The following is a description of a gene set: species: Homo sapiens Human Gene Set: GOBP_IMMUNE_RESPONSE_REGULATING_CELL_SURFACE_RECEPTOR_SIGNALING_PATHWAY The series of molecular signals initiated by an extracellular ligand binding to a receptor on the surface of the target cell capable of activating, perpetuating, or inhibiting an immune response., and this is the list of marker genes: CD40, NFAM1, TNIP2, LAPTM5, EP300, BTNL10P, TRAF3, CRKL, LIME1, KLRC4-KLRK1, RNF31, FCN2, HLA-A, RABGEF1, RFTN1, OAS1, GPS2, CD19, FCHO1, IFNG, IGHG4, PLEKHA1, NCKAP1L, SPG21, PVRIG, MAP3K7, FCGR2B, CD3E, IGHG1, CD300A, NFKB1, TRGC2, CYLD, MALT1 (MALT1 paracaspase), FCGR3A, TNFAIP3, BTN3A1, SIVA1 (NCBI Gene Id 89639), BTN2A2, CD160, PLCG2, KHDRBS1, MAPK8, VAV1, LAX1, CARD11, NFKBIA, FOXP1, LYN (NCBI Gene Id 4067), MYO1G, C3, SLC39A6, CD47, CD38, CD79B, ACOD1, CD81, WDFY1, VAV3, VAV2, NCR3, KLHL6, PAK1, PRKCD, ELF1, CD2AP, HLA-DPB1, UBASH3A, TEC, BTN3A3, CHUK, MS4A1, TREM2, HLA-DRB3, ITPRIPL1, TYROBP, SH2D1A, CLEC4D, PRKCQ, CD3G, PTPN22, KLRC2, FYB2, NOS2, MIR34A, PIK3AP1, RPS3, PLPP4, CD8A, IRAK2, STK11, FCN1 (NCBI Gene Id 2219), LILRB4, CMKLR1, RAP1A (NCBI Gene Id 5906), TLR4, CBLB, FCER1G, DGKZ, LIPA, FLOT1, CD3D, SH2B2, KCNN4, APPL1, TNFRSF21, FCGR3B, EIF2B4, MIR149, MEF2C, TRIL, IGKC, FCMR, LAT2, LGALS3, TRAF6, SCIMP, BMX, CACNB4, BTNL9, BTLA, F2RL1, FCGR1BP, TRDC (NCBI Gene Id 28526), PTPN2, LBP, HLA-DRB1, IGHM, TRAT1, NFATC2, ICOSLG (NCBI Gene Id 23308), RAB7B, HCK, MAP3K1, CD8B, FCER2, GPR33, PIGR, NR1H3, ECSIT, BAG6, ZNRF1, TRBC2, IGHA2, MIR210, TRBC1, LCK, CCR7, NECTIN2, TBK1, DAB2IP, MAP2K4, PTPRC, PIK3R1, FOSL2, NMI, PAWR, GCSAML, BLNK, SHB, MIR18A, TIRAP, S100A14, LAT, STOML2, LY96, LCP2, ERMAP (erythroblast membrane associated protein (Scianna blood group)), FOXP3, CD33, SKAP1, LILRB1, SRC, RAB11FIP2, HLA-G, FPR3, PRAM1, HMGB1, BLK, CR2 (complement C3d receptor 2), ZNF683, SQSTM1, SPPL3, TRAC, THEMIS, INPP5D, FYB1, NR1D1 (NCBI Gene Id 9572), GPLD1, PRKCE, IRAK4, MIR140, C5AR2, CD24, PIK3CA, CD72, MIR200C, BPIFB1, YES1, CLEC7A, IKBKB (NCBI Gene Id 3551), LPXN, RAB29, LILRA2, CMTM3, CD226, PSG9, CREBBP, GCSAM, TICAM1, THY1, APPL2, TLR2, CD28, BTNL8, PRKCB, ABL1, PLCG1, PLSCR1, RGCC, NFKBIZ, LGALS9, BTK, COLEC11, TESPA1, BTRC, BCAR1, CSK, MIR20A, MAP2K7, TLR1, EIF2B1, CLEC6A, PHPT1 (phosphohistidine phosphatase 1), TMEM126A, IGLC3, CLEC4E, HHLA2, NAGLU, SYK, KIR2DL1, FCGR2A, IGHA1, TICAM2, IGHD, BCL2, VTCN1, MNDA, FGR, BTNL3, GBP1, IGLC7, KLRK1, CTLA4, CD200R1, BTN2A1, IGHG3, GPR32P1, COLEC10, KLRC3 (killer cell lectin like receptor C3), UBE2N, FPR1, TLR5, FYN, CD79A, SLA2, TRGC1, FCN3 (NCBI Gene Id 8547), RELA, ZAP70, KLRD1, IFI35, NINJ1, MIR708, DENND1B, LETMD1, THEMIS2 (NCBI Gene Id 9473), CEACAM1, WNK1, CR1 (complement C3b/C4b receptor 1 (Knops blood group)), ITK, CLEC12B, MAPK10, BTN2A3P, PJA2, EIF2B2, PTPN6, TAX1BP1, BRAF, AKT1, LTF, CD276, TLR6, PTPRJ, FCAR, GRB2, RC3H1, DUSP3, FER, RIPK2, EIF2B3, IGHG2, FCRL3, PIK3CD, SOS1, PELI1, MAPK1, TRIM32, HLA-DQB1, MICB (NCBI Gene Id 91956), BTN1A1, DUSP22, FCER1A, MYD88, FCGR2C, C3AR1, CYBA, ZC3H12A, MIR200B, IKBKG, BANK1, PRKCH (protein kinase C eta), PTK2, LIMK1, MBL2, CD22, KIT, PLCL2, IGLC1, STAP1, NCK1, GATA3, BTN3A2, IGLC6, RC3H2, MOG, LILRA4 (NCBI Gene Id 23547), RBCK1, UBR2, CACNB3, FFAR2, C5AR1, KIR2DS2, SLC39A10, IRAK1, PDE4D, MIR19A, BCL10, KLRC4, EIF2B5, EZR, PAK2, PRKD2, FCGR1A, KLRC1, PSEN1, CD14, PDE4B (NCBI Gene Id 5142), PAK3, GPR32, ITGAM, MAPK9, BAX, TXK, PLA2G6, LILRB2, MIR146A, NFKBID, TNIP3, FPR2, BTNL2, CD247, ADA, HRAS, MFHAS1, PRNP, IGHE (NCBI Gene Id 388026), IRF3, NR4A3, PLD2